Given this list of marker genes PEG3, GEM, MYO1D, RAB3B, UBC, PRSS23, IGSF11, CASR, EFR3A, USP1, SV2A, MAP1A, RPL4, GNPDA1, RAB12, AHCTF1, ING2, TSHZ1, MTUS2, IGBP1, BBX, GFPT1, TOGARAM1 (TOG array regulator of axonemal microtubules 1), ARG2, SC5D, COPS2, ST8SIA3, PRKAR2B, ADRA2A, UNC80, CDV3, DDX3Y (DEAD-box helicase 3 Y-linked), MYO5A, CNBP (CCHC-type zinc finger nucleic acid binding protein), UBE2QL1, ZBTB4, TMEM109, SLK, AKAP11, IL6R, GHITM, TMEM126B, SEC63, CHD7, BRI3, ATP1B2, NRCAM, KLHL42, PLCB1, WDR7, RPL5, SCG3, TANC2, RAB3IP, TFCP2L1, MSANTD4, PIK3C2A, PLOD2, NDFIP1, ABCA5, SLC6A6, ACVR1, STXBP5, AFF4 (NCBI Gene Id 27125), CMTM8, MAGI2-AS3, SORL1, ERRFI1, PER3, MADD, C14orf132, CCNI, PDE4DIP, BNIP3, GIGYF2, DARS1, PAFAH1B1, CLASP2, C2CD5, STAG2, ATF6, GDAP1 (NCBI Gene Id 54332), PTPRN, PRMT2, RTCB, HAPSTR1, FOXN3, MAFG, RPL7A, TMEM33, ADM, MAP3K2, RAP1GAP2, HABP4, P2RY1 (purinergic receptor P2Y1), CREBRF, C15orf61, EXPH5, FKBP4, TRIQK, MRPL49, CADM1, RORA, ISCU, RPL36AL, RAB11FIP5, ISOC1, STX1A, CYFIP2, PCGF5, TGOLN2, UBE3C, TAGLN3, OLFM1 (NCBI Gene Id 22825), NPR2 (natriuretic peptide receptor 2), PRPF8, TCAF1, ZNF277, GNAS, TOMM20, SCD5, BEX1, SLAIN2, RASSF6, FAM8A1, MAPT, CLCN3, AZI2, GDA, NMRK1, LRRTM3, GREM1, CACNA1D, AKT3, ENSG00000291149, USP51, MXRA7, CANX, BCL2L2, RNF6, ARMCX3, C1D, EIF3H, ZNF204P (NCBI Gene Id 7754), SLC11A2, DICER1, PSD3, PTBP3, MT2A, MEIS2, PSAP, RCOR3, TMED6, RGL1, CASC3, INSM1 (NCBI Gene Id 8196), PPID, CACNA2D1, PHC2, PI4KA, APPL2 (NCBI Gene Id 55198), PPP1R1A, TSPAN13, PJA2, SLC25A34, PLCL2 (NCBI Gene Id 23228), APC, PKP2, KIF3B, RETREG2, GYG1, TBC1D24, PIP4P2, SETD3, RUNX1T1, TBC1D9B, HSPA1A, TRAPPC8, ABAT, ACVR1B, RAPH1, PDX1, CDC37L1 (cell division cycle 37 like 1, HSP90 cochaperone), ROBO1, ZC3H6, TRIB3, TSPYL1, MNX1, ANKH, ATP6V1C1, GOLGA8A, FAM222A, MDM2, APCDD1L-DT, MIA3, TNKS2, BEX2, TMOD2, PERP, ZNF746, TPRG1L, INSIG1, UBQLN2, RAB3GAP1 (NCBI Gene Id 338380), PCM1, TSPYL5, RASGRF1, PITHD1, FBXO7, SETD7, TERF2, EPB41L1, LARP1, NR0B1, USP9X, MPP1, PRUNE2, SHISAL1, SEC11C, BBS2, EIF4A2, BCL9, RTN4, SBDS, NAP1L2, MEG3, ARHGAP35, ABCG1, WDR17, ENO1, RNF2, HECTD1, BTBD3, UTRN, SLC4A10, HECTD4, EIF4G3, FKBP5, HMGCLL1, ANKMY2, ABHD10, IGSF1, STX3, RHEB, RMND5A, DMXL2, TBC1D4, TMEM38B, IPO7, SNX29, SURF2, IRF2BP2, MT1F, LRPPRC, MTSS1, MAPRE2, SMAD9, RABGGTB, RPS23, SLC7A1, RGS16, RPL31, NRDC, MRPL34, NAP1L5, SREBF1, ELP4, GTF3C1, CYP2U1, CDIP1, SLC4A7 (solute carrier family 4 member 7), DIP2C, DNAJC12, SNHG7, TNS1, GLIS2, HADH, FTH1P3, PREPL, DOCK10, OLMALINC, ABHD3, RBBP8, AACS, HCFC2, TSHZ3, U2SURP, EIF1B, PRPS1, DST, NAP1L1, LMO2, CIRBP, LPIN1, PPM1E, SCAPER, PCSK1, TOMM34, DENND5B, RCBTB2, FFAR4, ATP6V1G1, FAM219A, PTPN3, NECTIN3, PRKACB, TUBA4A, HSPA4L, BNIP3L (NCBI Gene Id 9257), VEGFA (NCBI Gene Id 7422), THAP5, KTN1, PARVB, XPOT, TBL1XR1, SHTN1, ROBO2, ATP6V1B2, SNHG32, CBX7, FXR1 (FMR1 autosomal homolog 1), CDC5L, PURB, RHOQ, ABCC8, GSN (gelsolin), RUFY3, MAP6, CSDE1, RPH3AL, SYT7, GNG4, SRPRA, SESN1, AP3B1, TMEM181, WARS1, SUSD6, TMEM64, NEFM, SRD5A1, BTG3, NAPA, ZMYND11, SYBU, VWDE, MEGF9, GOLGB1, ASAP1, ZMIZ1, SIX2 (SIX homeobox 2), ARHGEF3, OCIAD1, ITPR3, ZNF652, CAMLG, PTPRJ, C2orf69, ARL4D, MGAT4A, NFE2L1, AMPD2, PIM3, AGTPBP1, SARS1, RNF19B, PLCXD3, ZNF318, FOXO1, ATXN2, EDN3, ILF3-DT, IAPP, COBLL1, DGKD, HSP90AA1, NR3C1, TBCC, IER3, CLIP1, SYT4, UHMK1, NFIC, FTH1, KCNMA1, KLHL12, RRM2B, VPS13C, CFL2, KAT2B, MKRN2, CLTC, PSMC6, VAMP2 (NCBI Gene Id 6844), DBI, RNF157, RPS4X, SIPA1L2, KMT2C, RAB11FIP1, CEBPG (CCAAT enhancer binding protein gamma), HSPH1, CNP, ZNF292, HNRNPC, ETNK1, KIDINS220, ZNF770, TUBB2B, CRMP1, FAM135A (NCBI Gene Id 80266), ST13, CDK5R1, COMMD9, ST3GAL5, MAP1LC3A, RBP4, DPYSL2, PIGA, ABR, PAIP2, ERICH5, INPP5F, SLC25A4, PEBP1, NSG1, GAS5, SUCO, ZNF91, TRIP11, EIF3E, KIF13A, STMN3, PLEKHA6, DDX24, SBNO1, PGK1, MAN2A2, LETMD1, MIS18BP1, EPM2AIP1, ELAVL4, TLE5, TTC7B, PPT1, TSPAN1, ZNF331, KDM3A, GNG7, RANBP2, EPRS1, PLCB4, TPM3, CPD (NCBI Gene Id 1362), MCUB, METTL5, TAB2, BMP5, ENO2, MAFA, SEMA6D, ANKRD12, ZNF667-AS1, RALGPS1, BAG3, WNT4, SPIN1, RPL3, HPS4, COPS7A, RCAN2, APPL1, SHOC2, COPRS, CCT4, TOR1AIP1, ALCAM, ALKBH5, FBXO33, NEUROD1, JKAMP, RNF130, PDZD2, FAM107A, ELMO2 (engulfment and cell motility 2), HSPA1B, SH3GL2 (NCBI Gene Id 6456), CLGN (calmegin), CFAP68, NCOA4, CDK6, HSPA8, SLC1A4, RCAN3, HOPX, GSE1, CLTA, PRKAG2, DSP, CLCN4, DLK1, SRXN1, ECPAS, TSPAN7, ALDOC, KLF13, PTCH1, RNF187, PURA, SLC2A1, HAX1, MPHOSPH8, G6PC2, FOXJ3, VEGFB (vascular endothelial growth factor B, NCBI Gene Id 7423), ANKRD65, INA, SQSTM1 (NCBI Gene Id 94002), SLC2A2, TCAF2, PTAR1, SPRYD3, BTF3L4, UBQLN1, RIMKLA, GLIS3, DHRS7, DGKE, ATP6V1D, SURF4, SOBP, KCNK17, PRDM4, PDZD8, CADPS, MAP1B, SCD, RAB39B, TMEM65, ZNF395, ATP6V1A, HLTF, PATL1, PPM1A, CCSER2, WSB2, EFNA5 (ephrin A5), LINC01128, DNAJB1, PRKCH, ATP6V1E1, KCNG3, ARPP19, CNRIP1, RNF13 (ring finger protein 13), KCTD13, PHACTR2, GCC2, PDE8B, ZNF483, SLC39A14, CREB3L2, CDC42BPA, TCEA1, TMEM167A, FBXO17, EIF4B, CERK, TMOD1, EDARADD (NCBI Gene Id 128178), WAC, MTMR6, CPEB4, NORAD, CDKN1C, ZBTB33, PRXL2A, HSPA13, DPP6, RAB29, KIF21A, ST18, BEX4, AKTIP, PIKFYVE, RASD1, TMEM132B, NANOS1, HDAC9, SOCS2, MAP2, SYNE2, SUMO3, GLT8D2, ZMAT3, CACYBP, TRIM9, AFF1 (NCBI Gene Id 83116), DNAJC6, MATR3 (NCBI Gene Id 9782), FRA10AC1, FBXL16, CFAP36, CAPN7, UBXN1 (UBX domain protein 1), CAPN13, CAMK2N1 (calcium/calmodulin dependent protein kinase II inhibitor 1), NDRG1, PGRMC2, FAM200B, MTURN, TSPYL2, ATP8A1, CDC42EP3, GPM6A, ATP6V0E2, G3BP2, COX7A2L, SKIC3, DHRS2, SPECC1L, DDIT3, PRNP, KCNK3, TRMT112, MAPRE1, MARK1, VPS37A, RRN3, TUNAR, RPS3, VOPP1 (VOPP1 WW domain binding protein), PCDH7, ARFGEF2, TIMP2, SLC16A9, MYH14, GOLGA4, CHD9, NGRN, SERPINB4, NCKAP1, DDR1, SYT11, VLDLR, MIR4458HG, PHF1, TTC3P1, FAM174B, CACNA1H, EML6, PELI1, ENTPD3, KIF5B, PDZRN3, PTPN1, DSTYK, UCHL5, FLOT1, SCGN, FASN, SVIP (NCBI Gene Id 258010), RAB22A, NEXMIF, WLS, SSTR5-AS1, SCN1B, FGF9 (fibroblast growth factor 9), MYCBP2, NFASC, KIF1A, CDCP1, ZCRB1 (zinc finger CCHC-type and RNA binding motif containing 1), SLC25A36, HSPD1, PNMA2, UBXN4, MTSS2, DYNC1H1, TRIM2, TPD52, RAD17, PFN2, SPOPL, ESD, ME1, FYTTD1 (forty-two-three domain containing 1), SMAD7, ACLY, AP1AR, HACD3, ZZZ3, DLGAP4, DNAJC3, CRACD, RPL17, ACVR1C, TERF2IP, TXNL1, ARL6IP5, DYNLT3, OSBPL8, TRIM37, RNMT, TXNRD1 (thioredoxin reductase 1), MT1X (metallothionein 1X), CHN1 (chimerin 1), MTERF2, NEU1, PAN2, NAV2, JAZF1, SYNM, ASH1L, RPL37, HLF, KIF3A, DTX3, RPA2, USP12, SGMS2, MLXIPL, NCOA3, EPB41L3, EXOC2, VAPB, SETBP1, PPL, CENPC, PEPD, TTLL7, LNPK, MTERF4, GPRASP1, SNAP91, OTULINL, RRAGD, NISCH, BHLHE41, GNA13 (G protein subunit alpha 13), ROR1, BTBD1, KDM7A (lysine demethylase 7A), BRD7, ATP2A3, IQSEC1, FOXA2, RABEP1, FYN, GNAO1, CYYR1 (cysteine and tyrosine rich 1), PIR, GRPEL2 (NCBI Gene Id 134266), EXOC5, BTBD8, RASGRP1, TAOK1, CREBL2, KCNK16, ENPP5, MAN1A2, UCHL1, TMEM37, HUWE1, SERINC1, ATRX, BRD10, ADCYAP1, GPSM1, UBN1, TIAM1, WSCD2, NBEA, WFS1, AARS1, PSMB1, PSMD1, RAB15, PTGES3, ID4, NMNAT2, HIVEP2, SMIM29, MYO3A, MAST4, SAMD3, BLOC1S2, SLC6A17, SLC29A1, HS6ST1, PCLO, OLA1, MRPS18B, GABARAPL2, PKIB (cAMP-dependent protein kinase inhibitor beta), TMEM150C, HSPA9, ID1, PNMA8A, C12orf76, REPIN1, RASA4, PCMT1, ZBTB38, WHAMM, PPP1R2, PTPN11, ATP6V0A1, TRIM23, NEO1, NPTX2, MAN1C1, PRRC2B, TMCC3, MIR7-3HG, SNX9, DNAH5, SELENOW, ZNF106, C4orf3, USF3, IRS2, DNAJB9, CABP7, ANP32B, C21orf91, SLC2A13, TNFRSF11A, FNIP2, CELF4 (NCBI Gene Id 56853), THAP6, HSP90AB1, HOOK1, RERE, RRAGC, ADH5, KLF10, FNIP1, CLIP4, VPS35, GLCCI1, YME1L1, MCC, GAD2, LYSMD2, KATNAL1, GREM2, GABARAP, TPP1, PLAGL1, C1orf43, KCMF1, YWHAG, RAD50, SLC30A8 (NCBI Gene Id 169026), FTL, ARL8B, JUND, CISD2, PAPSS2, NKX2-2, SOCS7, IGF1R, GPR158 (G protein-coupled receptor 158), OSTM1, NEBL (NCBI Gene Id 51739), WDR33, ALG2, GRIA4, HERPUD1, PIPOX, LYST, MBD1, MAFB, SUSD4, CHL1, SPEG, ARHGEF9, SEMA5A, FMN2, MXI1, CDKN1A, EEF2, LONRF2, KLHDC10, ZCCHC14, ERO1B, LMAN1, USP34, TOMM70, NCOR2, ARHGAP5, TTC3, MBP, ROCK1, TGFBR3, ENDOD1, PALS2, KCNH2, THBD, PTEN, SHISAL2B, CD200, ORC3, ATG3, IL17RB, ZHX3, SPIRE1, RRAGA, INS, CBX4, KLHDC8A, USP48, XPC, RAB5A, NUS1, NIN, SIX3, KLHL2, NR1D2, UNC79, LDOC1, SYT13, ELMO1, TAF9 (NCBI Gene Id 6880), PNMA1, STMN2, FBXL17, ATRNL1, UBL3, KIF5C, ANO5, STXBP1, KAT6B, NUCKS1, ANP32E, PSIP1, PFKFB2, SLC18A2, VAT1L, KCNJ11, G3BP1, ABRACL, PPP2CB, ACAT1, EPB41L4A-AS1, here is a description of the gene set: studied in species Homo sapiens Human Gene Set: MURARO_PANCREAS_BETA_CELL from publication Muraro MJ, Dharmadhikari G, Grün D, Groen N, Dielen T, Jansen E, van Gurp L, Engelse MA, Carlotti F, de Koning EJ, van Oudenaarden A (PMID 27693023)